The following is a description of a gene set: Genes distinguishing asparaginase resistant and sensitive ALL (B- and T-lineage ALL); here - genes up-regulated in the drug resistant samples. Human Gene Set: HOLLEMAN_ASPARAGINASE_RESISTANCE_ALL_UP from publication Holleman A, Cheok MH, den Boer ML, Yang W, Veerman AJ, Kazemier KM, Pei D, Cheng C, Pui CH, Relling MV, Janka-Schaub GE, Pieters R, Evans WE (PMID 15295046) species: Homo sapiens Childhood acute lymphoblastic leukemia (ALL) is curable with chemotherapy in approximately 80 percent of patients. However, the cause of treatment failure in the remaining 20 percent of patients is largely unknown., and this is the list of marker genes: NPHP4, PTGER4, TENT5C, UBOX5, TAP2, CCDC69 (coiled-coil domain containing 69), MICAL3, RPL11 (NCBI Gene Id 6135), JMJD7-PLA2G4B, EIF3K (eukaryotic translation initiation factor 3 subunit K), NTRK3, CDR2, NOP53, BCR, RPS3, RPL7A, GALNS, GLDC, RPL3, EFHC1, LRP5L, RPL6, DPY19L1 (NCBI Gene Id 23333)